Given this list of marker genes RAC2, TMA7B, ENSG00000280424, EFCAB6-AS1, C22orf46P, KLHDC7B, SLC16A8, LINC00899, SGSM3, SHISA8, PRR34, MAFF, CYP2D8P, MIR658, RN7SKP210, NUP50-DT, TMEM184B, CHADL, SGSM3-AS1, ATF4, NUP50, POLDIP3, KDELR3, TAFA5, ACO2, RPL39P41 (NCBI Gene Id 100271532), CRELD2, RPL35P8, RIBC2, H1-0, TBC1D22A-DT, RPL5P34 (NCBI Gene Id 91698), CERK, TRABD-AS1, SHISAL1, PPARA, LGALS2, PICK1, MRTFA, SNRPA1P2, ATXN10, RN7SL704P, MEI1, SSTR3, TTLL1, RPS25P10, EPIC1, LINC00229, ENSG00000224715, ENSG00000230922, ZC3H7B, L3MBTL2-AS1 (L3MBTL2 antisense RNA 1), GTPBP1, PHF5A, L3MBTL2, A4GALT, PPP6R2, ENSG00000287225, NFAM1, RNU6ATAC22P, PDXP-DT, MAPK8IP2, MIR6821, IL17REL, PANX2, PDGFB, FAM118A, COX5BP7, MIR1249, UPK3A, PRR5, KIAA0930, RRP7A, ACR, EFCAB6-DT, SEPTIN3, RPL5P35, CHKB-DT, PRDX3P1, GTSE1 (G2 and S-phase expressed 1), TNRC6B-DT, RPL6P28, ARHGAP8, SKP1P4, PRR5-ARHGAP8, SNORD83A, ENSG00000303883, TSPO, LINC01644, UQCRFS1P1, CBY1, ENSG00000285722, APOBEC3A, APOBEC3D, CDC42EP1, GAPDHP37, NCAPH2, MCHR1, GGA1, FAM227A, MIR4535, TOMM22-DT, RNU6-375P, KRT18P23, LGALS1 (galectin 1), ANP32BP2, KCNJ4, RN7SKP80, XRCC6, ACTBP15, RNU6-476P, TTLL12, MGAT3, PARVG, MIR1281, WNT7B, BAIAP2L2, RBX1, SMIM45, SMC1B, TPTEP2-CSNK1E, MIR4534, HDAC10, RN7SKP252, NOL12, LMF2, ENSG00000306993, SNORD13P1 (NCBI Gene Id 6076), RNU12, TTLL1-AS1, MIRLET7A3, RANGAP1, LINC00898, RNU6-513P, TTLL8, NPTXR, SNORD43, TMEM184B-AS1, DNAL4, CARD10, SCUBE1-AS1, ARFGAP3, CELSR1, GRAMD4, ATP5MGL, PNPLA3, MIOX, SBF1, MIEF1, SCO2 (NCBI Gene Id 9997), TRNT1P2, LINC01656, ARSA, ADM2, SLC25A17, SCUBE1-AS2 (SCUBE1 antisense RNA 2), SHANK3, RPL3, CACNA1I, RNU6-1161P, TRABD, MLC1, PLXNB2 (plexin B2), CSNK1E, SELENOO, POLR2F, DNAJB7, MGAT3-AS1, SREBF2, SYCE3, PDXP, WBP2NL, RNU6-495P, MIRLET7BHG, FUNDC2P4, CHKB, TTC38, PHETA2, APOBEC3B-AS1, SERHL, TCF20, GALR3, APOBEC3H, ENSG00000273145, PNPLA5, RABL2B, CCDC134, LINC01315, MIRLET7B, TRIOBP, RPL7P52, RN7SL385P, CYB5R3, PMM1, ENSG00000281732, XPNPEP3, DMC1, FAM136EP, SNORD83B, ADSL, HMGN2P10, DESI1, SERHL2, MPPED1, CENPM, ALG12, DDX17, MIR6889, MFNG, CPT1B, RTL6 (NCBI Gene Id 84247), TYMP, SCUBE1, MTFR2P2, NDUFA6-DT, RPL23AP82, C22orf23, LINC00207, SELENOO-AS1, NAGA, TBC1D22A, MAPK12, ENSG00000235154, CDPF1, TNRC6B, MIR3201, HMGN2P9, MICALL1, OLA1P1, SH3BP1, APOBEC3B, MRPS18CP6, RFKP4, CYP2D6, PACSIN2, CIMAP1B, COA1P1, RPL35AP36, ENSG00000310070, GOLGA2P4, CYTH4, CYP2D7, TBC1D22A-AS1, PHF21B, RRP7BP, TUBGCP6, LINC01589, MIR4762, MIR3619, TRMU, MIR33A, LINC02939, MIR3667HG, MCAT (malonyl-CoA-acyl carrier protein transacylase), PIM3, NDUFA6, BIK, COX6B1P3, SNU13, OGFRP1, RNU6-409P, MIR6820, EP300, MIR4763, MOV10L1, ENSG00000290922, ST13, RNU6-379P, JTBP1, PARVB, ANKRD54, ADAMTS7P5, MIR378I, RPS19BP1, MIR3667, DENND6B, EFCAB6, CBX6, FAM83F, NHIP, SLC25A5P1, SREBF2-AS1, ENSG00000289963, TOMM22, CHKB-CPT1B, APOBEC3G, LRRC37A14P, KLHDC7B-DT, SOX10, RPS9P2, SYNGR1, ENSG00000306452, MIR4766, FBLN1, APOBEC3C, MIR659, RPL4P6, LINC01639, SAMM50, POLR3H (RNA polymerase III subunit H), APOBEC3F, RPS29P31, TNFRSF13C, LINC01310, MRTFA-AS1, PLA2G6, GCAT, GRAP2, ELFN2, ENSG00000308520, JOSD1, MIURF, ENTHD1 (NCBI Gene Id 150350), TOB2, ZBED4, SMDT1, TAB1, BRD1 (bromodomain containing 1), TPTEP2, RNU6-900P, CBX7, EIF3L, GTSE1-DT, ENSG00000225929, SUN2, PKDREJ, MAPK11, LINC02925, ENSG00000260613, SULT4A1, CSDC2, TEF, EP300-AS1 (EP300 antisense RNA 1), here is a description of the gene set: Human Gene Set: chr22q13 species: Homo sapiens